Given this list of marker genes APOC2, LPL, G6PC1, GPIHBP1, SLC37A4, APOE, here is a description of the gene set: Lipemia retinalis Human Gene Set: HP_LIPEMIA_RETINALIS studied in species Homo sapiens A creamy appearance of the retinal blood vessels that occurs when the concentration of lipids in the blood are extremely increased, with pale pink to milky white retinal vessels and altered pale reflexes from choroidal vasculature.